Given this list of marker genes Hdac3, Nf1, Mdfic, Park7, Akap1, Sumo1 (NCBI Gene Id 22218), Nfkbia, Rab23, Tpr, Fermt1, Cabp1, Pkia, Sp100, Sirt6, Ufm1, Txn1, Hnf4a, Chp1, Gbp4, Ei24, Cdk5, Pkig, Ywhab, Bard1, Angpt1, Fam76b, Apod, Rbm10 (RNA binding motif protein 10), Cd36, Nup153, Rangap1, Ddx39a, here is a description of the gene set: Mouse Gene Set: GOBP_NEGATIVE_REGULATION_OF_NUCLEOCYTOPLASMIC_TRANSPORT studied in species Mus musculus Any process that stops, prevents, or reduces the frequency, rate or extent of the directed movement of substances between the cytoplasm and the nucleus.